The following is a description of a gene set: Human Gene Set: GOCC_CENTRIOLE A cellular organelle, found close to the nucleus in many eukaryotic cells, consisting of a small cylinder with microtubular walls, 300-500 nm long and 150-250 nm in diameter. It contains nine short, parallel, peripheral microtubular fibrils, each fibril consisting of one complete microtubule fused to two incomplete microtubules. Cells usually have two centrioles, lying at right angles to each other. At division, each pair of centrioles generates another pair and the twin pairs form the pole of the mitotic spindle. species: Homo sapiens, and this is the list of marker genes: HAP1, WASH3P, RILPL1, ROCK1, DZIP1 (NCBI Gene Id 22873), CEP41, PLA2G3, CEP295, TUBGCP3, SAXO1, CCDC57, IFT52, CEP63, TSKS, RP2, IFT81, CEP290, TSSK2, CNTLN, PLK2, IFT43, CPLANE2, CEP295NL, MAPK15, CCHCR1, POC1A, BBS4, SFI1, WDR62, CIBAR2, KIF2A, INTU, ALMS1, AURKA, CEP135, CEP76, CEP250, HTT (huntingtin), RAB8A, TUBD1, CEP170 (centrosomal protein 170), HYLS1, CEP44, MKS1, CEP192, PLK1, CEP85, RAN, HERC2, TOP2A, CCDC78, AHI1, POC5, CEP97, CEP350, CCDC92, NPHP4, ENKD1, CCDC102B, CEP83, SIRT2, CEP78, CCSAP, CIBAR1 (NCBI Gene Id 730572), NEDD1, CROCC, SPICE1, TTBK2, TUBG1, CCNF, WRAP73, HSPA1B, ODF2L, IFT140, MPHOSPH9, AGBL3, MICALL1, FTCD, IQCB1, HSPA1A, CFAP20, LRRCC1, CCDC146, POC1B, CETN3, CEP120, SDCCAG8, AKNA, TEDC2, CETN1, STIL, KIAA0753, TSGA10, C2CD3 (NCBI Gene Id 26005), CCDC88A, FBXW8, IFT20, NIN, CBY1 (chibby 1, beta catenin antagonist), CEP131, CEP164, KIF3A, CCDC120, HSPA6, CEP128, BCCIP (NCBI Gene Id 56647), MDM1, WASHC1, CNTROB, CEP152, IFT88, DZIP1L, CCDC15, PARP3, C10orf90, AGBL2, TEDC1, DCTN1, PLK4, BIRC5, CENPJ, CEP20, CEP104, DYNC2I2 (dynein 2 intermediate chain 2), AGBL4, ODF2, TOPORS, SASS6, SAXO2, CROCC2, SMO, ODAD3, CEP89, KIF24, BNIP2, NUBP1, GLE1, CEP162, RTTN, CETN2, RAB34, CAPG, PPP1R35, CEP19, DEUP1, OFD1, RAB11A (RAB11A, member RAS oncogene family), FAM161A, WDR90, FBF1 (Fas binding factor 1), DNM2, MAGI2, ATXN10, CEP55, CFAP53, SCLT1, ARMC9 (armadillo repeat containing 9), CEP43, NEURL4, RABL2B, KIAA0586, CCP110, PCM1, CCDC68, STARD9, PCNT, NUBP2, SSNA1